Given this list of marker genes LMNA, IARS2, IFT27, SMAD4, BBS9, NRAS, SPRED2, BMPR1B, PDE6D, UBE4B, FBXO28, BPNT2, UPF3B, BBS4, FGD1, SDCCAG8, IFT81, PPM1D, NEPRO, WDR35, FTO, HHAT, CUL4B, PUM1, NSUN2, KIF7, GABRD, TLK2 (tousled like kinase 2), LTBP3, TRPS1, NOTCH2, IQSEC2, BAP1, MRAS, NXN, HOXA13, GJB3, KDSR, ZFPM2, RDH11, RB1, PORCN, PDE4D, EBF3, SHOC2, DYM, ALX3, TGFBR2, WDPCP, SUFU, AIFM1, SNRPN, PTPN11, PDE3A, RLIM, JAG1 (jagged canonical Notch ligand 1), GJB4, TMEM231, CEP55, SNX14, APC2, GJA8, DOCK6, SPART, EXTL3, YY1AP1, DYNC2LI1, PCYT1A, SOS1, KCNAB2, SEC23B, PDPN, BBS5, HSPG2, CHN1, KCNK4, RAB23, CHST11, DDX3X, DLL4, SKI, FLII, GATA4, ERF, CHRNA7, PTHLH, PIGK, IFT43, BGN, PDGFRB, CAMK2G, CTSK, RRAS, FGFR1, RAP1B, LBR, PAPSS2, LONP1, GNAS-AS1, SDHC, CEP120, MIR17HG, GPC4, CRIPT, WNT5A, KDR, TBX22, EXOSC2, TRPV4, ALX1, IFT122, AHSG, HOXD13, POMP, MAP3K7, CSGALNACT1, TWIST2, ESCO2, PIK3R1, BBS1, DPYSL5, KLF13, PTCH2, SLC2A1, PTCH1 (patched 1), PIGN, SMARCD2, PRKACB, AHDC1, EHMT1, TRIP11, KLLN, SMARCA2, RUNX2, GNAS, LZTFL1, NEK1, ATRX, OFD1, CCDC22, POP1, KIAA0586, RIN2, TFAP2B, B3GLCT, SLC35D1, SMC1A, MARS1, MBTPS1 (NCBI Gene Id 8720), TOPORS, NPHP1, IHH (Indian hedgehog signaling molecule), GDF5 (NCBI Gene Id 8200), LSS, FBN1, CWC27, FGFR2, GPX4, PCNT, TTC21B, EOGT, KRAS, DVL3, CSPP1, POR, BMP2, CDH11, RERE, MMP23B, LUZP1, WASHC5, GDF6, PRMT7, INPPL1, RBBP8, RHOA, RRAS2, PUF60, MAP2K1, FLNA, COL2A1, ERI1, ADAMTS10, MKS1, IFT74, CEP290 (centrosomal protein 290), BBS7, LTBP2, ARL6, USF3, ADNP, PIK3CA, KDM6A, REV3L, RAD21, BRAF, NLRP3, SIL1, PITX1, MIR140, NKX2-6, AKT1, PIGL, WNT7A, ATP7A, CCDC32, VPS35L, FAM149B1, DVL1, MED12, FZD2, DPF2, NOTCH1, PRDM16, GDF1, NKX2-5, KIF15, RAI1, PPP1CB, MACROH2A1, TRIO, WDR11 (WD repeat domain 11), COMP, MAF, MYCN, NOG (noggin), BBS12, CCDC28B, TRIM32 (NCBI Gene Id 3971), MYSM1, KCNJ2, IFT140, GATA5, FAM20C, ALG8, SCNM1, CASZ1, PLCB3, LIFR, ARHGAP31, BBIP1, PAH, SHOX, UBAP2L, MRPS16, CPLANE1, DONSON, ZMIZ1, GJA5, SCUBE3, BBS10, MAGEL2, DHCR7, ARID2, PGM3, TCTN3, ANTXR2, NIN, SALL4, HNRNPR, PNPLA6, FLT4, WAC, SLC26A2, COL11A2, DYNC2I2, DPH2, RIT1, KAT6B, SDHB (succinate dehydrogenase complex iron sulfur subunit B), MAFB, RNU4ATAC, SPECC1L, MSX2, TCF12, SEMA3E, RSPRY1, PTDSS1, RAF1, FBXW11, GLI3, DYNC2I1, TMEM67, PTEN, FGF9, BBS2, IFT57, CFAP418, ADAMTS17, DYNLT2B, SPEN, STAMBP, C12orf57, HDAC4, NBAS, ZIC1, ITGB6, HEATR3, PRKCZ, ALG6, LTBP1, DCPS, MKKS (NCBI Gene Id 8195), MYMX, GJA1, SLC35C1, WNT4, CHST3, SMC3, PAX3, PTH1R, TONSL (tonsoku like, DNA repair protein), BMP4, AFF4, ACAN, DEAF1, SIN3A, TBX5, ARID1A, ATP6V1B2, COL11A1, CHSY1, EVC, TTC8, CSNK2A1, MGAT2 (alpha-1,6-mannosyl-glycoprotein 2-beta-N-acetylglucosaminyltransferase), SCAPER, RBPJ, STX16, IFT80, KMT2D, POGZ, IFT52 (intraflagellar transport 52), KDM5C, CANT1, TBX1, SRCAP, SDHD, TELO2, POC1A, RMRP, CILK1, ROR2, FAM111A, PRKAR1A, KIAA0753, DBH, HRAS, GATA6, ZDHHC9, LIG4, MEGF8, PPP3CA, EXT1, FLNB, RASA2, KIF26A, SLURP1, GNB2, CITED2, TASP1, NPR2, BHLHA9, KDM1A, CBL, KAT6A, DYNC2H1, FGFR3, TMEM216, HUWE1, SMG9 (SMG9 nonsense mediated mRNA decay factor), SOS2, TBX15 (NCBI Gene Id 6913), PLXND1, CEP19, EFNB1, SIK3, GRB10, PIGS, EPB41L1, EVC2, SCLT1, IFT172, LZTR1, CHD7, GHR, TWIST1, MYMK, TNNT3, PRKAR1B, SH3PXD2B, WDR19, NIPBL, IGF2, here is a description of the gene set: species: Homo sapiens Digits that appear disproportionately short compared to the hand/foot. The word brachydactyly is used here to describe a series distinct patterns of shortened digits (brachydactyly types A-E). This is the sense used here. Brachydactyly Human Gene Set: HP_BRACHYDACTYLY